The following is a description of a gene set: part of: FOXO-mediated transcription Reactome Pathway: FOXO-mediated transcription of cell death genes studied in species Homo sapiens FOXO transcription factors promote expression of several pro-apoptotic genes, such as FASLG, PINK1, BCL2L11 (BIM), BCL6 and BBC3 (PUMA). FOXO-mediated induction of cell death genes is important during development, for example during nervous system development, where FOXO promotes neuronal death upon NGF withdrawal, and also contributes to the tumor-suppressive role of FOXO factors (Arimoto Ishida et al. 2004). FOXO1 transcriptional activity is implicated in the cell death of enteric nervous system (ENS) precursors. RET signaling, which activates PI3K/AKT signaling, leading to inhibition of FOXO mediated transcription, ensures survival of ENS precursors.<br>Transcription of the STK11 (LKB1) gene, encoding Serine/threonine-protein kinase STK11 (also known as Liver kinase B1), which regulates diverse cellular processes, including apoptosis, is directly stimulated by FOXO3 and FOXO4., and this is the list of marker genes: CREBBP, NFYC, DDIT3 (NCBI Gene Id 92982), BBC3, FOXO1, CITED2, FOXO3, BCL2L11, PINK1, FOXO4, BCL6, FASLG, EP300, NFYA, NFYB, STK11